The following is a description of a gene set: Catalysis of the movement of lipids from the exoplasmic to the cytosolic leaflet of a membrane, using energy from the hydrolysis of ATP. studied in species Mus musculus Mouse Gene Set: GOMF_FLIPPASE_ACTIVITY, and this is the list of marker genes: Atp8b5, Abcb1a, Abca4, Tmem30b, Atp8b1, Abca3, Atp8b2, Atp10d, Atp10a, Atp8a2, Atp11c, Atp10b, Atp8a1, Tmem30a, Mfsd2a, Atp11a, Abcb1b